Given this list of marker genes CD3D, HLA-DRB1, EVL, CD247, TRAV29DV5, LAT, CD101, FYB1, GRAP2, PAK1, WAS, LCK, HLA-DQA1, CD4 (CD4 molecule), PLCG2, HLA-DRA, PAK2, TRBV12-3, HLA-DRB3, CD3E, HLA-DRB4, HLA-DPA1, HLA-DRB5, TRBV7-9, ITK, HLA-DPB1, CD3G, TRAV19, ZAP70, HLA-DQA2, HLA-DQB1, HLA-DQB2 (NCBI Gene Id 3120), TRAC, ENAH, LCP2, NCK1, TRAV8-4, TRBC1, VASP, PAK3, PLCG1, here is a description of the gene set: studied in species Homo sapiens part of: TCR signaling In addition to serving as a scaffold via auto-phosphorylation, ZAP70 also phosphorylates a restricted set of substrates following TCR stimulation - including LAT (step 13) and LCP2. These substrates have been recognized to play pivotal role in TCR signaling by releasing second messengers. When phosphorylated, LAT and SLP-76 act as adaptor proteins which serve as nucleation points for the construction of a higher order signalosome: PLC-gamma1 (step 14) and GRAP2 (step 15) bind to the LAT on the phosphorylated tyrosine residues. LCP2 is then moved to the signalosome by interacting with the SH3 domains of GRAP2 using their proline rich sequences (step 16). Once LCP2 binds to GRAP2, three LCP2 acidic domain N-term tyrosine residues are phosphorylated by ZAP70 (step 17). These phospho-tyrosine residues act as binding sites to the SH2 domains of ITK (steps 18) and PLC-gamma1 (step 19). PLC-gamma1 is activated by dual phosphorylation on the tyrosine residues at positions 771, 783 and 1254 by ITK (step 20) and ZAP70 (step 21). Phosphorylated PLC-gamma1 subsequently detaches from LAT and LCP2 and translocates to the plasma membrane by binding to phosphatidylinositol-4,5-bisphosphate (PIP2) via its PH domain (step 22). PLC-gamma1 goes on to hydrolyse PIP2 to second messengers DAG and IP3 (step 23). These second messengers are involved in PKC and NF-kB activation and calcium mobilization. Reactome Pathway: Generation of second messenger molecules